The following is a description of a gene set: An abnormality of the anterior fontanelle, i.e., the cranial fontanelle that is located at the intersection of the coronal and sagittal sutures. Human Gene Set: HP_ABNORMAL_ANTERIOR_FONTANELLE_MORPHOLOGY Abnormal anterior fontanelle morphology studied in species Homo sapiens, and this is the list of marker genes: CCDC22, PEX5, RUNX2, EP300, COL11A1, P3H1, SMC3, SETBP1, BANF1, PEX26, CHUK, PPP2R5D, PEX14, ETFB, LRP2 (NCBI Gene Id 4036), DICER1, AMER1, SEC23A, ETFDH, PPIB, VPS35L, PEX1, VARS1, CDH11, FAT4, INTU, ASPA (NCBI Gene Id 443), DVL1, ADAMTS2, GLI2, B3GLCT, CBFB, COL1A1, PEX6 (NCBI Gene Id 5190), EBP, IFT140, HRAS, RNU12, HDAC4, DDX3X, ROR2, TOMM7, ATP6V1E1, HYMAI, PEX12, DSE, RTL1, NFASC, MED12, MMP2, ZFX, DCHS1, ORC1, MID1, NAA10, SLC25A19, DLK1, MTOR, MASP1, FLNA (NCBI Gene Id 8272), SH3PXD2B, ALG9, DEPDC5, PIGQ, CREBBP, NSUN2, PEX3, H19, ANKRD11, UBR1, LIG4, PEX10, ATR, SIX2, MEG3, NDUFAF3, ZIC1, PCGF2, PEX2, IGF2, DDR2, SMG9, NEPRO, FAM111A, WNT5A, FGFR3, PEX19 (NCBI Gene Id 7835), POLR3A, SKI, COL11A2, ANTXR1, PEX13, ATP6V0A2, PLAGL1, FGFR2 (NCBI Gene Id 2263), RECQL4, POR, NSMCE3, TBCE, SLC25A24, RNU4ATAC, COG4, COG8, GRB10, ATP7A, KLF1, CRTAP, ZMPSTE24, CDC45, CTSK, ATP6V1A, MYCN, ETFA, KIF7, COL1A2, MPDU1 (mannose-P-dolichol utilization defect 1), PEX11B, SOX9, ARX, RPS6KA3, PIEZO2 (piezo type mechanosensitive ion channel component 2), TALDO1, GLI3, TSHB, PEX16, WT1, NCAPG2, TWIST1, GH1, DPYSL5, COX5A, GNPTAB, GLIS3, NLRP3